Given this list of marker genes SC5D, DHCR24, DHCR7, HSD17B7, TM7SF2 (NCBI Gene Id 7108), MSMO1, EBP, NSDHL, CYP51A1, FDFT1, LSS, SQLE, LBR, here is a description of the gene set: Cholesterol biosynthesis. Pathway ID: N01624. Pathway type: Reference. Pathway class: nt06034 Cholesterol biosynthesis. Human Gene Set: KEGG_MEDICUS_REFERENCE_CHOLESTEROL_BIOSYNTHESIS Pathway Definition from KEGG: Farnesyl-PP -- FDFT1 >> SQLE >> LSS >> CYP51A1 >> (TM7SF2,LBR) >> MSMO1 >> NSDHL >> HSD17B7 >> DHCR24 >> EBP >> SC5D -> 7-DHC -- DHCR7 -> Cholesterol species: Homo sapiens